Given this list of marker genes SULT1B1, TPST1, PAPSS1, SULT1A1, SULT1A4, ABHD14B, SULT1A3, PAPSS2, SULT2A1, SULT1A2, SULT2B1, SULT1C4, SULT1C3, BPNT1, TPST2, ENPP1, SULT1E1, here is a description of the gene set: studied in species Homo sapiens Human Gene Set: GOBP_PURINE_NUCLEOSIDE_BISPHOSPHATE_METABOLIC_PROCESS The chemical reactions and pathways involving a purine nucleoside bisphosphate, a compound consisting of a purine base linked to a deoxyribose or ribose sugar esterified with one phosphate group attached to each of two different hydroxyl groups on the sugar.